The following is a description of a gene set: Mouse Gene Set: GOBP_REGULATION_OF_SPINDLE_ASSEMBLY Any process that modulates the rate, frequency or extent of spindle assembly. Spindle assembly is the aggregation, arrangement and bonding together of a set of components to form the spindle, the array of microtubules and associated molecules that serves to move duplicated chromosomes apart. studied in species Mus musculus, and this is the list of marker genes: Chmp5, Cenpj, Gpsm2, Sass6, Mapk15, Spag5, Dync1h1, Chmp4b, Stil, Chmp1a, Chmp2a (NCBI Gene Id 68953), Numa1, Hspa1b, Drg1, Tpr, Chmp3, Chmp2b, Chmp7, Eml3, Senp6, Rnf4, Vps4b, Ccsap, Chmp1b2 (NCBI Gene Id 74520), Plk1, Ripor2 (RHO family interacting cell polarization regulator 2), Chmp6, Rcc1, Cep97, Hspa1a, Hnrnpu, Chmp4c, Chmp1b